Given this list of marker genes DUOXA1, ILDR2, EBF1, MGLL, TVP23B, CCDC97, IQSEC3, CLNS1A, TJP1, ARL3, NNAT, ARHGAP42, EIF4EBP2, IPO8, KIF26A, STING1, MOGAT2, HIPK3, SLC4A8, ZNF704, TCF12, ARHGAP6, ADD2, CNOT2, HK1, DNAAF9, SFSWAP, PPARD, TNRC6B, SMARCD1, ZNF223, CAPN6, TMEM169, FOXO3, KCNMA1, CSMD2, GRID1, TEX261, MAPK6, ZHX2 (NCBI Gene Id 22882), SLC25A36, PEAK1, SHANK2, CALML4, ARFIP1, REPS2, ALPK3, URM1, SORBS2, RNF41, NKRF, PIAS2, ATG7, POU2F1, RMND5A, RPL22 (ribosomal protein L22), ATCAY, JAZF1, RTL5, DCP1A, SCN8A, XYLB, TSC1, RAI14, DLG3, SLC24A2, SMAD2, CREBZF, PACS2, MAPRE3, GLUD1, SPRING1, GRIK3, ZMYND8, PTP4A2, GAL3ST3, IGF1R, PNN, CAMK1D, MTCL2, SH3YL1, ZCCHC3, RAPGEF1, ARRB1, ZNF471, AGO4, TTC21B, DCUN1D2, PSRC1, MYO1D, NFASC, FAM219B, HIF1A, TMEM106C (transmembrane protein 106C), USP20, PDIA6, SIN3A (NCBI Gene Id 25942), PACSIN2 (NCBI Gene Id 150377), GRM1, LAMC3 (laminin subunit gamma 3), ULBP2, PAX9, ACVR2B, DHX35, GKAP1 (NCBI Gene Id 80318), TUT4, NEUROD1, SMIM21, SLC17A7, NUP153, ELMOD3, SNCAIP, FAM149B1, FAM227A, FAM107B, ATP2A2, TRAPPC9, HECTD2, CEP57L1, AGAP1, PPP2R5E, KPNA4, NFX1, RASSF8, UBXN10, ATP6V1E1, KCND2, SZT2, TCEAL5, EXOSC3, RALGPS1, ATXN2L, IFNB1, GPM6B, IGF2BP1, ERC1, ERMP1, ZNF827, ZIC2, ZMYND19, MSANTD3, here is a description of the gene set: Human Gene Set: MIR3692_5P Genes predicted to be targets of miRBase v22 microRNA hsa-miR-3692-5p in miRDB v6.0 with MirTarget v4 prediction scores > 80 (high confidence targets). species: Homo sapiens from publication Chen Y, Wang X (PMID 31504780)